Given this list of marker genes C3, CFD, CFP, CFB, GZMM, here is a description of the gene set: part of: Initial triggering of complement Reactome Pathway: Alternative complement activation The proteins participating in alternative pathway activation are C3 (and C3b), the factors B, D, and properdin. In the first place, alternative pathway activation is a positive feedback mechanism to increase C3b. When C3b binds covalently to sugars on a cell surface, it can become protected. Then Factor B binds to C3b. In the presence of Factor D, bound Factor B is cleaved to Ba and Bb. Bb contains the active site for a C3 convertase. Properdin then binds to C3bBb to stabilize the C3bBb convertase on cell surface leading to cleavage of C3. Finally, a C3bBb3b complex forms and this is a C5 convertase. studied in species Homo sapiens